The following is a description of a gene set: Genes up-regulated in hepatic stellar cells after stimulation with bacterial lipopolysacharide (LPS). Mouse Gene Set: SEKI_INFLAMMATORY_RESPONSE_LPS_UP studied in species Mus musculus from publication Seki E, De Minicis S, Osterreicher CH, Kluwe J, Osawa Y, Brenner DA, Schwabe RF (PMID 17952090) Hepatic injury is associated with a defective intestinal barrier and increased hepatic exposure to bacterial products. Here we report that the intestinal bacterial microflora and a functional Toll-like receptor 4 (TLR4), but not TLR2, are required for hepatic fibrogenesis. Using Tlr4-chimeric mice and in vivo lipopolysaccharide (LPS) challenge, we demonstrate that quiescent hepatic stellate cells (HSCs), the main precursors for myofibroblasts in the liver, are the predominant target through which TLR4 ligands promote fibrogenesis. In quiescent HSCs, TLR4 activation not only upregulates chemokine secretion and induces chemotaxis of Kupffer cells, but also downregulates the transforming growth factor (TGF)-beta pseudoreceptor Bambi to sensitize HSCs to TGF-beta-induced signals and allow for unrestricted activation by Kupffer cells. LPS-induced Bambi downregulation and sensitization to TGF-beta is mediated by a MyD88-NF-kappaB-dependent pathway. Accordingly, Myd88-deficient mice have decreased hepatic fibrosis. Thus, modulation of TGF-beta signaling by a TLR4-MyD88-NF-kappaB axis provides a novel link between proinflammatory and profibrogenic signals., and this is the list of marker genes: Nfkbie, Tjp2, Egfr, Cxcl3, Ifi47, Neurl3, Zmynd15, Slc11a2, Cemip2, Lratd1, Tnip1, Sh3pxd2b, Cd40, Stx11, Slc4a7, Sele, Csf1, Egr3 (NCBI Gene Id 13655), Gsap, Prrx1, Slco4a1, Egr2, Slc15a3, Ereg (NCBI Gene Id 269673), Ripk2, Casp4 (NCBI Gene Id 12363), Cxcl2, Ptpre, Adamts7, Gbp2, Tlr2, Serpina3g, Cxcl16, Gbp6, Ccl7, Gpr68, Gch1, Plk2, Btg1, Jdp2, Cxcl10, Rel, Ngfr, Ier3, Birc3, Icosl, Osmr, Abcb1b, Fas, Sod2, Gbp3, Lif, Cd44, Exoc3l4, Ccrl2, Schip1, Nfkbiz, Maff, Gbp2b, Rnd1, Cxcl5, Zc3h12a, Ccl2, Rab20, Tslp, Fosl1, Gadd45b, Tcim (transcriptional and immune response regulator), Nfkbia, Icam1, Rfx5, Ccl3, Nfkb2, Birc2 (NCBI Gene Id 77616), Vcam1, Rsad2, Tnfaip2, Egr1, Tnfaip3, Bmp2